The following is a description of a gene set: Human Gene Set: HP_ABNORMAL_SLEEP_ARCHITECTURE Abnormal sleep architecture species: Homo sapiens Interruptions during the various stages of sleep., and this is the list of marker genes: IQSEC2, RAI1, PRNP, DEAF1, FLII